The following is a description of a gene set: Human Gene Set: GOBP_BRAIN_DERIVED_NEUROTROPHIC_FACTOR_RECEPTOR_SIGNALING_PATHWAY The series of molecular signals generated as a consequence of a brain-derived neurotrophic factor receptor binding to one of its physiological ligands. species: Homo sapiens, and this is the list of marker genes: RAPGEF2, FSTL4, NTRK2, BDNF, VPS13A, SLC2A4, NFATC4